The following is a description of a gene set: species: Homo sapiens Pigment migration into the retina in a bone-spicule configuration (resembling the nucleated cells within the lacuna of bone). Human Gene Set: HP_BONE_SPICULE_PIGMENTATION_OF_THE_RETINA Bone spicule pigmentation of the retina, and this is the list of marker genes: PRPF6, BBS1, GUCA1B, ARHGEF18, RBP3, LCA5, RAX2, CC2D2A, BBS2, MFRP, PRPF4 (NCBI Gene Id 9128), ATF6, CNNM4, BEST1, CLRN1, REEP6, CERKL (ceramide kinase like), NRL, TLCD3B, FSCN2, RDH12, RPGR, RRM2B, TTLL5, KIAA1549, TULP1, RP9, PDE6A, NR2E3, RGR, PISD, PCARE, TRNT1, IFT88, UNC119, CNGA1, MERTK, CCDC28B, RLBP1, CFAP418, RP1L1, SEMA4A, IFT172, AIPL1, GUCY2D, AHI1, OPN1LW, CNGB1 (cyclic nucleotide gated channel subunit beta 1), CNGA3, SNRNP200, TTC8, IDH3A, GUCA1A, GRM6 (NCBI Gene Id 2916), RPGRIP1, LRAT, ADAM9, RAB28, OFD1, CLCC1, ZNF513, CHM, PDE6G, IMPG2, TUB, CRX, MAK, LZTFL1, RP2, EYS, AHR, VPS13B, CACNA2D4, IFT140, ARSG, KLHL7, ZNF408, PDE6B (NCBI Gene Id 5158), ARL6, ROM1, SAG, DRAM2, FAM161A, ABCA4, SPATA7, USH2A, OPN1MW, IDH3B, RIMS1, PRPH2, DHX38, MKS1, AGBL5, BBS5, HK1, DHDDS, CDHR1, IMPG1, ARL2BP, IMPDH1, NMNAT1, CA4, CFAP410, RPE65, FLVCR1 (NCBI Gene Id 559), PROM1, PRCD, POC1B, CACNA1F, RDH11, NEK2, SCAPER, PITPNM3, CRB1, PRPF31, BBS9, RHO, IFT43, ARL3, PRPF8, PRPF3, KIZ, RP1, SLC7A14, TOPORS, POMGNT1, HGSNAT